Given this list of marker genes STAT1, ERBB2, VEGFA, JAK1, EGF, EGFR, STAT3, here is a description of the gene set: Human Gene Set: KEGG_MEDICUS_VARIANT_ERBB2_OVEREXPRESSION_TO_EGF_JAK_STAT_SIGNALING_PATHWAY ERBB2-overexpression to EGF-Jak-STAT signaling pathway. Pathway ID: N00095. Pathway type: Variant. Pathway class: nt06262 Pancreatic cancer. Pathway Definition from KEGG: EGF -> (ERBB2*+EGFR) -> JAK1 -> STAT1/3 => VEGFA species: Homo sapiens